The following is a description of a gene set: Genes having at least one occurence of the motif GTCAGGA in their 3' untranslated region. The motif represents putative target (that is, seed match) of human mature miRNA hsa-miR-378 (v7.1 miRBase). Human Gene Set: GTCAGGA_MIR378 studied in species Homo sapiens, and this is the list of marker genes: CAMKK2, MAP3K11, SAMD4B, PRR3, C3orf70, SHC3, ROBO2, KCNH5, TRIAP1, NDEL1, GABBR2, OGT, ATP2B2, FGF5, KPNA1, ABR, PYM1, TUSC2, BNIP5, REPS1, GALNTL6, LRP12, ST8SIA4, NEBL, NFIX, NF1, SLC7A1, FAM133B (NCBI Gene Id 257415), CRB1, CCDC178, YTHDF2, KLF9, ENSA, CCDC88A, SUFU, RIN2, ANAPC1P2 (NCBI Gene Id 285074), UBE2W (ubiquitin conjugating enzyme E2 W), NSD2, CEP41, B3GALT1, TAB3, MPLKIP, DTNA, LBR, CCDC117, FOXN3, HS6ST2, BCLAF3 (BCLAF1 and THRAP3 family member 3), VANGL2, ETV6, TRIM13, SAP30L, TMUB2, TOM1L2 (target of myb1 like 2 membrane trafficking protein), PGR, GABPA, KBTBD4, GNAQ